Given this list of marker genes Exoc7, Stard3, Trappc3, 5730455P16Rik, Trappc6a, Naglu, Trappc12, Trappc13, Trappc4, Trappc9, Exoc3, Tbc1d23, Trappc5, Trappc6b, Exoc1, Trappc2, Exoc8, Exoc6, Exoc5, Trip11, Trappc2l, Trappc10, Exoc2 (exocyst complex component 2), Exoc4, Fam91a1, Trappc1, Exoc6b, Wdr11, Trappc11, Stard3nl, here is a description of the gene set: studied in species Mus musculus The initial, indirect interaction between a vesicle membrane and a membrane to which it is targeted for fusion. This interaction is mediated by tethering factors (or complexes), which interact with both membranes. Interaction can occur via direct binding to membrane phospholipids or membrane proteins, or via binding to vesicle coat proteins. This process is distinct from and prior to interaction between factors involved in fusion. Mouse Gene Set: GOBP_VESICLE_TETHERING